Given this list of marker genes RNF167, HAO2, PLEKHG2, CCND2, PAIP2, RPL32, NCOA2, AMPD3, MFNG, RPLP1, IER5 (immediate early response 5), USPL1, RPS11, CCNY (cyclin Y), GIMAP6, CBR1, DCDC2B, PDK1, UBLCP1, TMEM31, SLC25A22, TMEM259, AKAP8L, ARSK (arylsulfatase family member K, NCBI Gene Id 153642), DTX1, RFLNB, KDM5B (NCBI Gene Id 10765), CCM2, FAS, OMP, PI4K2A, STAT6, TSACC, ZXDB, TLR1, NCOA4, AGRN (agrin), RPL4, TRMU, KMT5B, SPATA6, MLYCD (NCBI Gene Id 23417), RAMP1, IDS (NCBI Gene Id 3423), EPS8L1, ABTB3, PAXX, RPS27, MEF2D, CCR9 (NCBI Gene Id 2851), RBCK1, TAMALIN, RPL27A, IFIT3, TASOR2, MTERF4, RBM39 (NCBI Gene Id 9584), HMGXB3, NPC2, RPL19, PDE7A, TNFAIP8L2, PIGV, KLHL28, RAB12, RPL35, PPIC, NSD3, TNIP1, GALNT6, SH3GL1, PIK3IP1, RSRP1, KLHL24, NTPCR, RPL11, UBN2, SKI, RPL13, RPS7, DOCK10 (dedicator of cytokinesis 10), ZNF777, CELF1, CNGA1, CHST15, RASGRF2, ZZEF1, METTL25B, ANKRD13D, KDM6A, PPP1R13B, KLF13, MYCBP2 (NCBI Gene Id 55685), TMEM71, RBM6, MAPDA, UBR2, TCN2, HDAC5, STX2, BMF, PPP1R3F, PRKCB, ABTB1, PRRC2C, KRIT1, INHBB, B3GALNT2, WLS, BCL11B, RASGEF1A, KLB, CXXC5, THYN1, TEC, TRIM56, SIPA1L2, PKNOX1, SLFN12L, RPS14, IRF2BP2, TNFRSF1A, POLR3F, GPANK1, DEDD2, RIOK2, IL6ST, RPL37, GLG1, ZDHHC13, RLF, ZBTB4, CTU2, IL6R, TANC1, RFXANK, RPL7, RGCC, YEATS2, ARID5A, LIMD1, NPRL3, RHOA, CTSS, TCP11L2, CD84, CCDC88C, TREML2, SAMTOR (NCBI Gene Id 154743), ST8SIA1, ERCC5, STK4, INTS13, CARD6 (caspase recruitment domain family member 6), TRMO, RPL22, GAS6, NR3C1, RGP1, NINJ1, RPL38, ZBTB26 (zinc finger and BTB domain containing 26), NFKBID (NFKB inhibitor delta), TMEM108, SLC37A1, RAB2B, TMA7, LPAR6, SCYL3, USP53, MINDY2, DRC1, DPH7 (diphthamide biosynthesis 7), C21orf91, SSH2, CCDC102A, WDR59, ZFP82, AMPD1, C11orf68, ALS2CL, FAM50A, ORMDL3, NR1D2, ADGRL1, DVL1, PRKD3, ACP6, DNAJC28, BACE1, MED13L, DUSP11, IRF9, SOCS3, TEX264, DNAJC17, MYO5B (myosin VB), RNF130, SELPLG, here is a description of the gene set: from publication Sarkar S, Kalia V, Haining WN, Konieczny BT, Subramaniam S, Ahmed R (PMID 18316415) Using killer cell lectin-like receptor G1 as a marker to distinguish terminal effector cells from memory precursors, we found that despite their diverse cell fates both subsets possessed remarkably similar gene expression profiles and functioned as equally potent killer cells. However, only the memory precursors were capable of making IL-2 thus defining a novel effector cell that was cytotoxic, expressed granzyme B, and produced inflammatory cytokines in addition to IL-2. This effector population then differentiated into long-lived protective memory T cells capable of self-renewal and rapid re-call responses. Mechanistic studies showed that cells that continued to receive antigenic stimulation during the later stages of infection were more likely to become terminal effectors. Importantly, curtailing antigenic stimulation towards the tail-end of the acute infection enhanced the generation of memory cells. These studies support the decreasing potential model of memory differentiation and show that the duration of antigenic stimulation is a critical regulator of memory formation species: Homo sapiens Genes up-regulated in comparison of naive CD8 T cells versus effector CD8 T cells KLRG1 Int. Human Gene Set: GSE10239_NAIVE_VS_KLRG1INT_EFF_CD8_TCELL_UP